Given this list of marker genes DSG2, CCND1, OVOL2, FOXE3, REG3A, FST, ACVRL1, SRSF6, NKX6-3, EZH2, MIR495, FOXJ2, YAP1, STAT1, MMP9, NODAL, DLL1, SPRY1, MIR18B (microRNA 18b), SPRED2, HES5, SOX9, FRZB, MIR518B, NOTCH4, MSX2, HOXA7, TP63, NOTCH1, JAG1, IFNG, CTNNB1, MSX1, MIR1-1, FGF10, HES1, IL13, SIX2, TBX3, SPRED3, SMO, SPRED1, GDF3, REG3G, CAV1, SPRY2, MIR29B1, EXTL3, S1PR3, VEGFA, OSR1, KRAS (KRAS proto-oncogene, GTPase), MIR302A, ZEB1, MIR10A, here is a description of the gene set: Any process that stops, prevents, or reduces the frequency, rate or extent of epithelial cell differentiation. Human Gene Set: GOBP_NEGATIVE_REGULATION_OF_EPITHELIAL_CELL_DIFFERENTIATION species: Homo sapiens